Given this list of marker genes Tbc1d24, Oxr1, Txn1, Ncoa7, Snta1, here is a description of the gene set: Mouse Gene Set: GOBP_REGULATION_OF_PEPTIDYL_CYSTEINE_S_NITROSYLATION studied in species Mus musculus Any process that modulates the frequency, rate or extent of peptidyl-cysteine S-nitrosylation.